The following is a description of a gene set: A type of holoprosencephaly in which most of the right and left cerebral hemispheres and lateral ventricles are separated but the most rostral aspect of the telencephalon, the frontal lobes, are fused, especially ventrally. Human Gene Set: HP_LOBAR_HOLOPROSENCEPHALY species: Homo sapiens Lobar holoprosencephaly, and this is the list of marker genes: KDM6A, TMEM231, TCTN2, TMEM67, CEP290, PTCH1, TMEM107, MKS1, RPGRIP1, TXNDC15, ZIC2, RAD21, RTTN, RPGRIP1L, TCTN1, CNOT1, TMEM237 (NCBI Gene Id 65062), TMEM216, B9D2, CSPP1, TGIF1, TCTN3, CC2D2A, FGFR1, KMT2D, B9D1